The following is a description of a gene set: Synthesis of PA species: Mus musculus Mouse Gene Set: REACTOME_SYNTHESIS_OF_PA, and this is the list of marker genes: Pla2g5, Pla2g4a, Pla2g2e, Gpd1l, Pla2g12a, Pld6, Lpcat1, Alpi, Gpam, Gpat3, Lclat1, Pla2g4d, Pla2g2a, Gpd2, Acp6, Miga2, Ddhd2, Miga1, Pla2g4b, Gpat4, Agpat4, Gnpat, Gpat2, Pld2, Pla2r1, Agpat1, Pla2g1b, Pla2g2f, Pla2g10, Lipi, Agpat3, Gpd1, Liph, Pla2g2d, Lpcat4, Ddhd1, Agpat5, Agpat2